The following is a description of a gene set: Human Gene Set: WP_IL18_SIGNALING IL18 signaling species: Homo sapiens, and this is the list of marker genes: TP53, CD81, IRF6, NCF1 (NCBI Gene Id 653844), CHUK, STOML1, CYCS, TNFAIP2, PLA2G7, BPGM, PTX3, NDUFC1, CD83, LMNB2, NFKB1, MAP3K7, MMP13, CNTN2, IL18R1, CCL20, REL, NACA (nascent polypeptide associated complex subunit alpha), PLCG1, SYT10, NR4A1, CCL2, NFKBIA (NFKB inhibitor alpha), IL18RAP, CCL18, GATA1, EEF2, IL2RA, PHF20 (NCBI Gene Id 80330), CD36, CCL19, RPS11, NSMF, HMOX1, NFATC4, KLF2, HPS1, RELA, ZNF143, FADD, NCAPH2, SEMA6D, CTNNB1, ARFGAP2, APBA2, STMN1, CEBPB, IL9, TRPC2, PRCC, DEK (NCBI Gene Id 7913), IER3, PRKCB, FAM110A, TACR1, BMP2, PKN1, NR1H3, MMP3, ULBP2, NPPA, KLC1, GRIN2B, MMP14, MEF2A, NOS2, CCNA2, COL1A2, CCN4, SDC4 (NCBI Gene Id 6385), CETP, GSK3B (NCBI Gene Id 2932), KCNH2, IL1B, CPT1A, IL17RC, NCF2, IL6 (NCBI Gene Id 3569), TOMM40, ZNF444, MMP9, MYH7, IKBKB, SLC12A3, IL10, CCL1, PRM1, BAZ1B, DES, TNFRSF11B, ENO1, MAPK1, ZDHHC7, MBTPS1, LRRFIP1, ARFGAP1, CSN2, NOX1, NFKBIZ, S1PR4, IRF1, IRAK1, BCL2L1, TNFRSF1A, ABHD16A, MAPK9, BID, IL12B, IL18, TNIP3, CASP3, TRPC4AP, GRM7, RANGAP1, SLC4A7, B2M, AARS1, PYGB, CASP8, VEGFA (NCBI Gene Id 7422), BAX, UGT2B10, IL13, LARS2, EPS8, KITLG, NPPB, PTPN7, ADIPOQ, CCL5, CA11, PIK3R1, MMP8, MMP1, PIGT, BTG2, HOXD8, MYD88, TRPM7, PWWP3A (NCBI Gene Id 84939), ZC3H12A, UGGT1, CXCL8, CLDN1, CLDN15, CLDN12, PTPRZ1, HDAC3, USP5, TMSB4X, FN1, ANP32A, CXCL16, TF, TIMP3, RASA3, RPS6KB1, TRAF6, ADAMTS5, PARP1, ALS2, CDK5R2, ACTA1, RUSC1, CXCL2, SPON1, SP1, MYH6, ZBTB7A, NRN1, BSG, MAP2K7, KRT31, PLOD3, IFNG, FAS, PRKCD, MEPCE, MAPK3, RND2, ARF6, PTMS, COL3A1, CCL3, CCNB2, CENPB, RUNX2, SEMA6C (semaphorin 6C), BIRC3 (baculoviral IAP repeat containing 3), PRKAA1, FOS, LONP2, NFKB2, CCDC9, ABCF1, CFLAR, ARL4D, ITGA2B, BIN1, NR0B2, PPT2, BAD, ATF3, TIMP1, TMEM165, RGS16, TNFSF11, TSHZ1, SPP1 (secreted phosphoprotein 1), FBXW7, COL1A1, PLD1, TRAF1, LTB, HSPB8, SOCS3 (NCBI Gene Id 9021), RFX5, TBX21, STK40, GRN, FAM186B, FOXN3, ACOD1, TNFAIP3, TGM2, PTGS2, BCL2, UCK1, TNF, CRYGC, NFKBIE, ARG1, IL37, HADH, HDGF, MMP2, CCL4, CLDN4, HCAR2, PRKCA, CXCL3, TICAM2, HSPB1, IL18BP (NCBI Gene Id 10068), ECH1, ACACB, SNTB1, IMP3, FUT1, ICAM1, ELAVL1, ITM2C, PTEN, JUN, PPP1R13L, LCK, KIFC3, RPTOR, FASLG, ACADS, GPAT4 (glycerol-3-phosphate acyltransferase 4), EPB41, MTCH1, RXRB, ZNF219, CLDN3, RAE1, ACTA2, COX17